The following is a description of a gene set: Mouse Gene Set: CUI_T_CELL_CD8_IGF_I_RESPONSE_DN Genes negatively differentially expressed in cell type: CD8+ T cell upon treatment with cytokine: IGF-1 in mouse lymph nodes in vivo. Cytokines mediate cell-cell communication in the immune system and represent important therapeutic targets. A myriad of studies have highlighted their central role in immune function, yet we lack a global view of the cellular responses of each immune cell type to each cytokine. To address this gap, the authors created the Immune Dictionary, a compendium of single-cell transcriptomic profiles of more than 17 immune cell types in response to each of 86 cytokines (>1,400 cytokine-cell type combinations) in mouse lymph nodes in vivo. A cytokine-centric view of the dictionary revealed that most cytokines induce highly cell-type-specific responses. For example, the inflammatory cytokine interleukin-1β induces distinct gene programmes in almost every cell type. A cell-type-centric view of the dictionary identified more than 66 cytokine-driven cellular polarization states across immune cell types, including previously uncharacterized states such as an interleukin-18-induced polyfunctional natural killer cell state. from publication Cui A, Huang T, Li S, Ma A, Pérez JL, Sander C, Keskin DB, Wu CJ, Fraenkel E, Hacohen N (PMID 38057668) species: Mus musculus, and this is the list of marker genes: Klf6, Fos, Hspa1a, Uba52, Hspa1b (NCBI Gene Id 15511)